Given this list of marker genes ADRB2, HLA-DRA, BTBD8, LDLRAP1, CD4, VAMP2, ROR2, CD3G, AREG, AP2A2, AP2S1, SLC2A8, EREG, IGF2R, WNT5A, AVPR2, SCARB2, CHRM2, SGIP1, HLA-DPA1, TBC1D5, VAMP4, LRP2, HLA-DQA1, HLA-DRB3, EGF, AP2M1, SH3GL2, HBEGF, VAMP7, STON1, TF (transferrin), HLA-DRB5, LDLR, HLA-DRB4, CD3D, CD74, HLA-DPB1, RAB5A, HLA-DQB2, TYRP1, IL7R, TGOLN2, CFTR, SYT2, EPGN, VAMP3, CD207, EPS15, BTC, APOB, KIAA0319, FCGR1A, SYT1, STON2, FZD4, CLTC, APOE, AP2A1, FZD5, AP2B1, EGFR, SYT9, FCGR1BP, SLC18A3, TFRC, AVP, HLA-DRB1 (major histocompatibility complex, class II, DR beta 1), VAMP8, HLA-DQB1, RAB35, TGFA, FZD2, M6PR, HLA-DQA2, CD9, here is a description of the gene set: species: Homo sapiens Human Gene Set: GOCC_CLATHRIN_COATED_ENDOCYTIC_VESICLE_MEMBRANE The lipid bilayer surrounding a clathrin-coated endocytic vesicle.